Given this list of marker genes ABCA7, MAP1A, TM9SF4, TMEM35A, GPD1L, TYROBP, MIR520B, LRIG2 (leucine rich repeats and immunoglobulin like domains 2), COMMD1, CD247, ABCA12, STX4, TNF, RANGRF, MIR520E, FCER1G, STX3, SNX33, RIC3, EPHB2, AKT1, ERBB4 (erb-b2 receptor tyrosine kinase 4), HSP90AB1, here is a description of the gene set: Any process that activates or increases the frequency, rate or extent of protein localization to the cell surface. species: Homo sapiens Human Gene Set: GOBP_POSITIVE_REGULATION_OF_PROTEIN_LOCALIZATION_TO_CELL_SURFACE